Given this list of marker genes Yme1l1 (YME1-like 1 (S. cerevisiae)), Opa1, Mfn1, Zdhhc6, Prkn, Mief1, Pld6, here is a description of the gene set: Mouse Gene Set: GOBP_POSITIVE_REGULATION_OF_MITOCHONDRIAL_FUSION Any process that increases the frequency, rate or extent of merging of two or more mitochondria within a cell to form a single compartment. species: Mus musculus